Given this list of marker genes CDC6, CCNE2, CCNE1, PTTG1 (PTTG1 regulator of sister chromatid separation, securin), CDK4, CDC25A, CHEK1, PLK1, CCNB2, E2F3, SMAD3, ORC2, BUB1B, MDM2 (MDM2 proto-oncogene), CDK1, MCM7, E2F1, SMC1A, PTTG2, ORC3, CHEK2, CCND3, CDKN2A, CDC7, MCM5, CCNB1, WEE1, BUB1, PRKDC, DBF4, CDC45, TP53, CCNA1, HDAC2, CCND2, CDC25C, MAD1L1 (mitotic arrest deficient 1 like 1), CDKN1A, MCM2 (NCBI Gene Id 94687), CDC20, MAD2L1, BUB3, E2F5, CDK2, ORC1 (NCBI Gene Id 4998), TFDP1, MCM6, MCM3, PKMYT1, HDAC1, ESPL1, CCNA2, CDK6, MCM4, PCNA, CDC25B, here is a description of the gene set: Human Gene Set: MODULE_57 Genes in the cancer module 57. studied in species Homo sapiens